Given this list of marker genes VSX1, TACSTD2, CTNS, GNA11, SLC39A14, ZEB1, TCF4, OVOL2, SF3B1, SLC4A11, COL17A1, AGBL1, COL8A2, TGFBI, GNAQ, CYSLTR2, GRHL2, BAP1, CHST6, SCN9A, here is a description of the gene set: An unpleasant sensation characterized by physical discomfort (such as pricking, throbbing, or aching) localized to the eye. Ocular pain species: Homo sapiens Human Gene Set: HP_OCULAR_PAIN